Given this list of marker genes Vcp, Nploc4, Faf1, Afg2b, Faf2, Ubxn1, Rnf125, Ubxn7, Ufd1, here is a description of the gene set: Mouse Gene Set: GOCC_VCP_NPL4_UFD1_AAA_ATPASE_COMPLEX studied in species Mus musculus A multiprotein ATPase complex required for the efficient dislocation of ER-lumenal degradation substrates, and their subsequent proteolysis by the proteasome. In budding yeast, this complex includes Cdc48p, Npl4p and Ufd1p proteins. In mammals, this complex includes a hexamer of VCP/p97 (a cytosolic ATPase) and trimers of each of its cofactors UFD1L and NPL4 (NPLOC4) (e.g. a 6:3:3 stoichiometry).